The following is a description of a gene set: The gene expression program underlying the specification of human cell types is of fundamental interest. The study authors generated human cell atlases of gene expression and chromatin accessibility in fetal tissues. For gene expression, the study authors applied three-level combinatorial indexing to >110 samples representing 15 organs, ultimately profiling ~4 million single cells. The study authors leveraged the literature and other atlases to identify and annotate hundreds of cell types and subtypes, both within and across tissues. Our analyses focused on organ-specific specializations of broadly distributed cell types (such as blood, endothelial, and epithelial), sites of fetal erythropoiesis (which notably included the adrenal gland), and integration with mouse developmental atlases (such as conserved specification of blood cells). These data represent a rich resource for the exploration of in vivo human gene expression in diverse tissues and cell types. Human Gene Set: DESCARTES_MAIN_FETAL_SLC24A4_PEX5L_POSITIVE_CELLS from publication Cao J, O'Day DR, Pliner HA, Kingsley PD, Deng M, Daza RM, Zager MA, Aldinger KA, Blecher-Gonen R, Zhang F, Spielmann M, Palis J, Doherty D, Steemers FJ, Glass IA, Trapnell C, Shendure J (PMID 33184181) Marker genes curated from the annotated cluster as represented in the Descartes Human Gene Expression During Development database. studied in species Homo sapiens, and this is the list of marker genes: TMEM200C, ADCY2, SLC22A13, TMEM35A, ZIM2-AS1, GRM7, LINC01210, VSTM2A-OT1, OVCH1, C8orf34, PREX2, HTR1E, C8orf34-AS1, VSTM2L, GRM3, LUZP2, DMBX1, GRIK4, RNU6-78P, GPR139, SSTR1, LINC01151, CLEC2A